Given this list of marker genes PIK3CA, ICOS, PIK3CD, PIK3R3, PIK3R5, PIK3CB, PIK3R1, PIK3R2, PIK3R6, ICOSLG, PIK3CG, here is a description of the gene set: studied in species Homo sapiens Human Gene Set: REACTOME_CO_STIMULATION_BY_ICOS Co-stimulation by ICOS